The following is a description of a gene set: Binding to a copper (Cu) ion. Human Gene Set: GOMF_COPPER_ION_BINDING species: Homo sapiens, and this is the list of marker genes: S100A12, LOXL3, ATP13A2, ALB, COX17 (cytochrome c oxidase copper chaperone COX17), APOA4, IL1A, GPC1, MT3, MUC2, SOD3, PRNP, OR5AR1, TYR, MOXD1, MOXD2P (monooxygenase DBH like 2, pseudogene), SUMF1, LOXL4, S100A13, COA6, S100A5, ANG, SNCG, PARK7, RNF7, DBH, LOXL1, SNAI3, SCO1, AOC3, LOXL2, AOC2, SNCB (synuclein beta), CUTA, ATOX1 (NCBI Gene Id 475), HEPH, AOC1, SOD1, ACR, P2RX4, PAM, SNCA, COX11, SLC31A1, F8, COMMD1, PRND, MTCO2P12, TP53, CCS, ATP7A, HEPHL1, DCT, MT-CO2, CP, ADNP, CUTC, LACC1, LOX, F5, SCO2, ATP7B